The following is a description of a gene set: Effects of SOCS3 on the transcriptional response of bone marrow-derived macrophages to IL-6. Fetal liver cells from SOCS3+/+ or SOCS3-/- embryos were used to reconstitute recipient mice. Donor derived bone marrow from these mice was differentiated to macrophages. Macrophages were either unstimulated, or stimulated for 100 or 400 minutes with 10 ng/ml IL-6. species: Homo sapiens from publication Lang R, Pauleau AL, Parganas E, Takahashi Y, Mages J, Ihle JN, Rutschman R, Murray PJ (PMID 12754506) Genes down-regulated in macrophages: untreated versus IL6 for 100min. Human Gene Set: GSE411_UNSTIM_VS_100MIN_IL6_STIM_MACROPHAGE_DN, and this is the list of marker genes: NLRC3, TMC6, MED12, TUBA4A, TMEM87B, PJA2, CAST, CD46, TRIM7, FAM210B (family with sequence similarity 210 member B), MORC3, SLC37A1, IFIT1, AZI2, ATRAID, ALG2, ITIH5, ETV3, HLA-DOA, PSKH1, CHD1L, CMTM7, PRRC1, CHMP1B, KHK (NCBI Gene Id 3795), DTX3L, ZFP3, TMEM50B, TSPAN2, ARRDC3, ZNF507, BBS4, C18orf21, ABHD11, CDK16, SAYSD1, MAP3K8, VPS4B, PIBF1, C16orf90, SHISA5, PDCL, C8orf33, CRB3, BCLAF1, CHIC1 (cysteine rich hydrophobic domain 1), TMED3, CD84, ZNF784, LEF1, CFAP96, HEXB, PISD, TTC33, DUSP7, SLC4A11, S100A6, SFXN3, RREB1, LAMB3, TNN, NCF1, MAT2A, TLE3, RFFL, S1PR1, CHM, YPEL2, C19orf38, UBTD2, NFRKB, ITK, SDF4 (stromal cell derived factor 4), CALCOCO1, GIMAP1, AIDA, HTATSF1, DDX5, ARID3B, FAM149B1, RBL2, PBXIP1, AP4B1, AMPD3, GRAP2, ZMYM2, TRAF3, BOD1L1, METTL21A, ZSCAN26, ABL1, NPC2, MYO1F, HLA-DRA, MAN1A1, CRLF3, RASSF5, POLR3D, CHD2, SLCO5A1, GALNT4, GPR183, CNR2 (NCBI Gene Id 1269), TRMT6, RHBDF2, RAD52, SNX2, PROX2, TNRC18, RNASEL, B4GALT5, NIBAN3, CARMIL1, DDRGK1, ZNF383, PDE8B, GALNT11, HOOK3, TMCC3, TNFRSF13B, NNT, PGLS, CREBL2, GLCE, S100A11, ADAM19, ANKRD44, TSPAN32, EFCAB14, DHRS7, GOLGA5, PDZK1, GPCPD1 (glycerophosphocholine phosphodiesterase 1), KCTD14, YDJC, PSTK, CASP8, EPS8L1, CEP97, ARHGAP9, CDC42SE2, PPM1L (protein phosphatase, Mg2+/Mn2+ dependent 1L), EZH1 (NCBI Gene Id 2145), TGFBR2, ALCAM, TBC1D17, TBC1D14, IFNAR1 (NCBI Gene Id 3454), FCRL1, GNMT, ADGRE1, BCL2L2, FAM120B, CD22, ZC3H6, AP5M1, SBNO2, NSG2, WWC2 (NCBI Gene Id 80014), CIITA (class II major histocompatibility complex transactivator), FILIP1L, SPAST, INCA1, CISD3, CACFD1, KMO, SLC35B3, HSD17B8, CD40, PHC3, RELCH, CASP1, FUCA1, PTPN6, CTPS2, ANXA5, TSHB, RELA, C3orf33, BTLA (B and T lymphocyte associated), RGS14, MBOAT7, HVCN1, MCL1, SLC16A6, BAHD1, ZNF629, AKAP12, LDB1, KLHL36, FBXW10, ADCK1, NAPSA, PACS1, DICER1, EPB41L4A, DIP2B, POGLUT1, VAV3, TBC1D10C